Given this list of marker genes ITPRIPL2, KLF4, SLA, IFI27L1, NPAS3 (neuronal PAS domain protein 3), ASNS, DNAJC12, ALDH1L2, LINC00900, WARS1, CORO1A, KIF21B (NCBI Gene Id 54770), DMGDH, CPNE8, WFDC2, ERN1, GALNT3 (NCBI Gene Id 2591), SLC7A5, PCK2 (NCBI Gene Id 5106), STC2, STOM, VMP1, FAM106A, RBP1, ADRB1, TRAF3IP3, TPBG, TMC8, TBC1D16, CEBPG, RTL5, VLDLR, RTN3, MTHFD2, PCDH20, XPOT, KCNK12, RAB31, HADH, INHBE, PHGDH, GPR63, STING1, EIF4EBP1, TM6SF1, LAMP5, ASS1, PCDH18, GPT2, RAB33A, CEBPB (CCAAT enhancer binding protein beta), G0S2, KLHL4, DCC (NCBI Gene Id 1630), SESN2, TRIB3, HS3ST3B1, MIA2, LURAP1L, ITGAL, SETD7, NID2, MAP1B, ARMCX1, NIBAN1, SLC7A11, ASB2, P2RX7, ATF5, here is a description of the gene set: from publication Zhan F, Huang Y, Colla S, Stewart JP, Hanamura I, Gupta S, Epstein J, Yaccoby S, Sawyer J, Burington B, Anaissie E, Hollmig K, Pineda-Roman M, Tricot G, van Rhee F, Walker R, Zangari M, Crowley J, Barlogie B, Shaughnessy JD Jr (PMID 16728703) studied in species Homo sapiens Human Gene Set: ZHAN_MULTIPLE_MYELOMA_CD1_VS_CD2_UP Genes up-regulated in CD-1 compared to CD-2 cluster of multiple myeloma samples. To better define the molecular basis of multiple myeloma (MM), we performed unsupervised hierarchic clustering of mRNA expression profiles in CD138-enriched plasma cells from 414 newly diagnosed patients who went on to receive high-dose therapy and tandem stem cell transplants. Seven disease subtypes were validated that were strongly influenced by known genetic lesions, such as c-MAF- and MAFB-, CCND1- and CCND3-, and MMSET-activating translocations and hyperdiploidy. Indicative of the deregulation of common pathways by gene orthologs, common gene signatures were observed in cases with c-MAF and MAFB activation and CCND1 and CCND3 activation, the latter consisting of 2 subgroups, one characterized by expression of the early B-cell markers CD20 and PAX5. A low incidence of focal bone disease distinguished one and increased expression of proliferation-associated genes of another novel subgroup. Comprising varying fractions of each of the other 6 subgroups, the proliferation subgroup dominated at relapse, suggesting that this signature is linked to disease progression. Proliferation and MMSET-spike groups were characterized by significant overexpression of genes mapping to chromosome 1q, and both exhibited a poor prognosis relative to the other groups. A subset of cases with a predominating myeloid gene expression signature, excluded from the profiling analyses, had more favorable baseline characteristics and superior prognosis to those lacking this signature.